The following is a description of a gene set: Human Gene Set: WP_10Q1121Q1123_COPY_NUMBER_VARIATION_SYNDROME species: Homo sapiens 10q11.21q11.23 copy number variation syndrome, and this is the list of marker genes: UVSSA, C10orf53, PARG, ERCC5, SMAD1, DRGX (dorsal root ganglia homeobox), WDFY4, MEN1, CLOCK, ITCH, BMP2, FRMPD2 (FERM and PDZ domain containing 2), NOG, SMAD5, DEK, ATF2, LRRC18, DLD, RGMB, BCL2, NEO1 (NCBI Gene Id 4756), RIF1, BMAL1, SMARCB1, SMARCA5, SMAD9, ELK1, FAM170B, CUL5, SIRT6 (sirtuin 6), DLST, ELOA, PCNA, SMARCC2, ERCC6, CDH1, C10orf71, HSF1, MAPK8, VSTM4, BMPR1A, GDF5, CHAT, ERCC8, SF3B1, HSF4 (NCBI Gene Id 3299), MYO1C, BAZ1B, SLC18A3, SIRT1, EIF4ENIF1, JUND, MYBBP1A, KDM4D, ARHGAP22, MIR4294, OGDHL, DDX21 (NCBI Gene Id 9188), BMPR1B, NLRP3, TMEM273